The following is a description of a gene set: species: Mus musculus Reactome Pathway: Regulation of CDH1 Function This event has been computationally inferred from an event that has been demonstrated in another species.<p>The inference is based on the homology mapping from PANTHER. Briefly, reactions for which all involved PhysicalEntities (in input, output and catalyst) have a mapped orthologue/paralogue (for complexes at least 75% of components must have a mapping) are inferred to the other species. part of: Regulation of CDH1 Expression and Function electronically inferred by orthology from the curated human pathway, and this is the list of marker genes: Psma7, Psmd12, Psma4, Actg2 (NCBI Gene Id 11468), Ctss, Psma3, Rps27a, Acta1, Fyn, Psmb4, Psma6, Psma5 (NCBI Gene Id 26442), Psma2, Actc1, Psmc3, Psmd13, Psmc2, Psma1, Ubb, Psmb7, Psmc5, Psmd7 (proteasome (prosome, macropain) 26S subunit, non-ATPase, 7), Psmc6, Cdh1, Psmb5, Dnm2, Mtbp, Psmc1, Psmc4, Psmd6, Banp, Ctnnb1, Rack1, Psmd1, Cbll1, Psmb6, Jup (NCBI Gene Id 16480)